Given this list of marker genes STX17 (NCBI Gene Id 9485), STX7, YKT6, VAMP8, SNAP29, here is a description of the gene set: studied in species Homo sapiens Pathway Definition from KEGG: (VAMP8,STX7) == SNAP29 == (STX17,YKT6) Human Gene Set: KEGG_MEDICUS_REFERENCE_AUTOPHAGOSOME_AND_LYSOSOME_FUSION_TRANS_SNARE Autophagosome and lysosome fusion, trans-SNARE. Pathway ID: N01720. Pathway type: Reference. Pathway class: nt06532 Autophagy.